Given this list of marker genes ANGPT1, EPAS1 (NCBI Gene Id 2034), TNFAIP2, PBX3, FGF1, IL18 (interleukin 18), TNFSF12, VEGFD, NRG1, KDR, PTPRR, JAG1, CXCL8, FGF6, TGFBI, ANPEP, FGF2 (NCBI Gene Id 2247), MMP19, here is a description of the gene set: Human Gene Set: MODULE_444 studied in species Homo sapiens Genes in the cancer module 444.